Given this list of marker genes Timm13, Timm10b, Timm9, Timm8a1, Timm10, here is a description of the gene set: Soluble complex of the mitochondrial intermembrane space composed of various combinations of small Tim proteins; acts as a protein transporter to guide proteins to the Tim22 complex for insertion into the mitochondrial inner membrane. studied in species Mus musculus Mouse Gene Set: GOCC_MITOCHONDRIAL_INTERMEMBRANE_SPACE_PROTEIN_TRANSPORTER_COMPLEX